Given this list of marker genes RFC3, RFC5, RFC2, RFC4, RFC1, here is a description of the gene set: A complex that loads the DNA polymerase processivity factor proliferating cell nuclear antigen (PCNA) onto DNA, thereby permitting processive DNA synthesis catalyzed by DNA polymerase. In eukaryotes the complex consists of five polypeptides. Human Gene Set: GOCC_DNA_REPLICATION_FACTOR_C_COMPLEX species: Homo sapiens